The following is a description of a gene set: The process in which nerve cells are generated in the forebrain. This includes the production of neuroblasts from and their differentiation into neurons. Mouse Gene Set: GOBP_FOREBRAIN_GENERATION_OF_NEURONS studied in species Mus musculus, and this is the list of marker genes: Pafah1b1, Drd2, Mir141, Mir376a, Sall1, Fgfr1 (NCBI Gene Id 14182), Mir9-3, Sall3, Sox1, Erbb4, Dlx1, Uncx, Dicer1, Slc4a10, Scyl2, Lrp6, Id4, Ogdh, Pou3f4, Lypd6, Csf1r, Slit2, Gbx2, Atp7a, Nr2e1 (nuclear receptor subfamily 2, group E, member 1), Rac1, Tfap2a, Eomes, Rapgef2, Ophn1, B2m, Neurog2, Shank3, Lhx5, Rac3, Rhoa, Nrp2, Secisbp2, Sema3a, Ptger3, Nfix, Elavl4, Nkx2-1, Mir429, Inhba, Gdpd5, Disc1, Arx, Pax6, Otp, Tbr1, Mettl3, Hes5, Dct, Hprt1, Fgf8, Lhx6, Atg7, Foxg1, Nrp1, Ndnf, Tfap2c, Aspm, Cntn2, Chd5, Mettl14, Lef1, Dclk2, Sox2, Dlx2, Dlx5, Dcx, Nhlh2, Ascl1, Robo1, Fgfr2, Bcl11b, Wnt3a, Ubb (NCBI Gene Id 22187), Plxna1, Zfp335, Prox1, Plxna3, Mir200b, Lhx8, Mir9-1, Gnaq, Gsx2, Zmiz1, Atf5, Wnt5a, Zdhhc16, Mir200a, Robo2, Gata2, Sema3e, Psen1, Smarcc2, Sin3a, Tox, Hes1, Mir200c, Pex5, Fezf2, Zswim6, Drd1, Gli3, D16Ertd472e, Emx1, Mir9-2, Uqcrq, Kcnq2